The following is a description of a gene set: studied in species Mus musculus Any process that activates or increases the frequency, rate or extent of membrane protein ectodomain peptidolysis. Mouse Gene Set: GOBP_POSITIVE_REGULATION_OF_MEMBRANE_PROTEIN_ECTODOMAIN_PROTEOLYSIS, and this is the list of marker genes: Ifng, Tnf, Adra2a, Snx9 (sorting nexin 9), Sh3d19, Gpld1, App, Adam9, Nrdc, Adam8, Rgma, Pacsin3, Apoe, Snx33, Il1b, Tnfrsf1b